Given this list of marker genes ING3, KAT8, ING4, JADE2, JADE1, KAT5, KAT7, KAT6A, here is a description of the gene set: Human Gene Set: GOMF_HISTONE_H4K16_ACETYLTRANSFERASE_ACTIVITY studied in species Homo sapiens Catalysis of the reaction: acetyl-CoA + histone H4 L-lysine (position 16) = CoA + histone H4 N6-acetyl-L-lysine (position 16). This reaction represents the addition of an acetyl group to the lysine at position 16 of histone H4.